Given this list of marker genes Heg1, Thy1, Chordc1, Rasip1, Synpo2, here is a description of the gene set: Mouse Gene Set: GOBP_REGULATION_OF_RHO_DEPENDENT_PROTEIN_SERINE_THREONINE_KINASE_ACTIVITY studied in species Mus musculus Any process that modulates the frequency, rate or extent of Rho-dependent protein serine/threonine kinase activity.